The following is a description of a gene set: Ankle swelling Human Gene Set: HP_ANKLE_SWELLING species: Homo sapiens, and this is the list of marker genes: STAT4, GJC2, MAFB, ANKRD55, PTPN2, IL2RA, ANGPT2, PTPN22, PIEZO1, FLT4, CD247, IL2RB